The following is a description of a gene set: Any process that modulates the frequency, rate or extent of type B pancreatic cell proliferation. studied in species Homo sapiens Human Gene Set: GOBP_REGULATION_OF_TYPE_B_PANCREATIC_CELL_PROLIFERATION, and this is the list of marker genes: FMC1, IRS2, SGPP2, NR1D1, IGF1, NUPR1, PTPRN, CDK4, PDX1, PHOX2B, NR4A1, WDR13, ERRFI1, NR4A3